Given this list of marker genes Pgam1, Bmp2, Tcl1b5, Mxd1, Pappa (NCBI Gene Id 71487), Il1rap, Zfp563, Dpysl5, Myh11, Comt, Selp, Tmem72, Snca (NCBI Gene Id 20617), Dpysl2, Cdadc1, Pkib, Cd209f, Fgf12, Map3k9, Gmnc, Nxpe3, Psd4, Osbp2, Guca1b, Stat5b, Zfp503, Dgkq, here is a description of the gene set: species: Mus musculus from publication Chen Y, Wang X (PMID 31504780) Genes predicted to be targets of miRBase v22 microRNA mmu_miR_7014_5p in miRDB v6.0 with MirTarget v4 prediction scores > 80 (high confidence targets). Mouse Gene Set: MIR_7014_5P